The following is a description of a gene set: Human Gene Set: MIR1244 Genes predicted to be targets of miRBase v22 microRNA hsa-miR-1244 in miRDB v6.0 with MirTarget v4 prediction scores > 80 (high confidence targets). from publication Chen Y, Wang X (PMID 31504780) species: Homo sapiens, and this is the list of marker genes: GLUD1, DENND4C, CSRP2 (NCBI Gene Id 7882), CYB5A, ARHGAP20, AGFG1, COL12A1, CCDC144A, TMEM184C, PIK3C2A, STYK1, SLC30A9, RHEB, EPC1, BIRC6, STX12, WNK1, NRIP1, ALDH8A1, FBXO11, CDC14A, TRIM71, ARL6IP1, PPP1R9A, DCP1B, ACOX1, CYRIA, ZBTB25, TRIM9, NOVA1, KCNN2, C9orf153, YIPF4, G3BP2, TUT7, F8, ATXN1L (ataxin 1 like), NIPSNAP3A, WDR7, ITPK1, MYBL1, C9, TAFA1, THAP2, DAPK1, RANBP3L (RAN binding protein 3 like), TOX, NCR3LG1, SATL1, PBX2, CDK17, ATP4B, DENND1B, AMZ2, PON2, NEDD4, TENM1, DCK, SEC24A, PHF6, GRK3 (G protein-coupled receptor kinase 3), GNAL, ABHD3, FBXO25, SLC30A5, NCOR1, SMURF2, ADRA1A, LIN28B, SYTL2, TSPAN14, TNIK, ZNF682, IL33, ADD3, SERPINE2, PRKCB, ANKRD44, EBF2, CREBRF, CSPP1, VBP1, PAWR, TANC1, PIK3C2G, OSBP, CEP85L, ITM2A (NCBI Gene Id 9452), DYNC1I1, EMC7, ARHGEF3, CRBN, MAP3K2, PABIR1, RPS6KA6, RC3H1, ADGRL4, MAP9